The following is a description of a gene set: Human Gene Set: GOBP_BLOOD_COAGULATION_FIBRIN_CLOT_FORMATION A protein activation cascade that contributes to blood coagulation and consists of the cascade of enzymatic reactions initiated by physical damage to the wall of a blood vessel, leading to the formation of a formation of a fibrin clot at the site of the injury. The process also includes numerous positive and negative regulatory events. species: Homo sapiens, and this is the list of marker genes: GP1BA, GP9, FGA, F13B, GP5, APOH, FGB, F12, FBLN1, F13A1, F8, FLNA, ITGB3, THBD, GP1BB, FGG